The following is a description of a gene set: species: Homo sapiens Although IRAK-1 was originally thought to be a key mediator of TRAF6 activation in the IL1R/TLR signaling (Dong W et al. 2006), recent studies showed that IRAK-2, but not IRAK-1, led to TRAF6 polyubiquitination (Keating SE et al 2007). IRAK-2 loss-of-function mutants, with mutated TRAF6-binding motifs, could no longer activate NF-kB and could no longer stimulate TRAF-6 ubiquitination (Keating SE et al 2007). Furthermore, the proxyvirus protein A52 - an inhibitor of all IL-1R/TLR pathways to NF-kB activation, was found to interact with both IRAK-2 and TRAF6, but not IRAK-1. Further work showed that A52 inhibits IRAK-2 functions, whereas association with TRAF6 results in A52-induced MAPK activation. The strong inhibition effect of A52 was also observed on the TLR3-NFkB axis and this observation led to the discovery that IRAK-2 is recruited to TLR3 to activate NF-kB (Keating SE et al 2007). Thus, A52 possibly inhibits MyD88-independent TLR3 pathways to NF-kB via targeting IRAK-2 as it does for other IL-1R/TLR pathways, although it remains unclear how IRAK-2 is involved in TLR3 signaling.<p>IRAK-2 was shown to have two TRAF6 binding motifs that are responsible for initiating TRAF6 signaling transduction (Ye H et al 2002). Reactome Pathway: IRAK2 mediated activation of TAK1 complex part of: MyD88 cascade initiated on plasma membrane; MyD88:MAL(TIRAP) cascade initiated on plasma membrane, and this is the list of marker genes: TRAF6, UBC, TAB2, IRAK2, MAP3K7, RPS27A, TAB3, UBB, TAB1, UBA52